Given this list of marker genes H2bc27, Terf1, H2ax, H4c9, Kat5, H2bc3, Nbn, Lmnb1, H1f5, H4c6, H2ac12, H4c14, H2ac19, H4c18, Cdkn1a, H2bc7, H2bc12, H4c1, H2ac15, H4c2, H2bc9, H4c3 (NCBI Gene Id 319155), H2ac4, H4c11, Hmga1, H2ac7, Acd, H2ac22, Ccna1, Trp53, H2bc11, Terf2, H4c17, Ccne1, H4c12, Cdkn1b, H2ac11, H1f3, H2az2 (NCBI Gene Id 77605), H2ac23, H1f1 (H1.1 linker histone, cluster member), H2ac8, H2ac24, H2ac13, Mre11a, H2bc22 (NCBI Gene Id 319188), H2bc8 (H2B clustered histone 8), Ep400, H2bc13, H4c4, Rb1, H2bc1, H2ac1, H1f4, H2ac10, H2ac6, H4c8, H2bc15, Ccne2, H2ac20, here is a description of the gene set: This event has been computationally inferred from an event that has been demonstrated in another species.<p>The inference is based on the homology mapping from PANTHER. Briefly, reactions for which all involved PhysicalEntities (in input, output and catalyst) have a mapped orthologue/paralogue (for complexes at least 75% of components must have a mapping) are inferred to the other species. part of: Cellular Senescence studied in species Mus musculus Reactome Pathway: DNA Damage/Telomere Stress Induced Senescence electronically inferred by orthology from the curated human pathway